Given this list of marker genes MYH14, ALDOA, RGS8, IL11, TAGLN2, NTN4, FABP4, ZNF827, NCDN, SCRN1, MIDEAS, EIF3J, PLEC, SYT2, FAP, SYN1, VWA7, GKN1, RTN4, MMP1, AKAP1, BDKRB1, KCNA2, SNCB, CDKN1A, TRAF3, GIT1, CYTOR, FAM180A, GFAP (glial fibrillary acidic protein), PSMD7, GABARAPL1, SRPK2, KRT19, RNF144B, GIGYF2, BRD2, EIF4G1, CFL2, MAP2, LRRC8E (leucine rich repeat containing 8 VRAC subunit E), MNT, EIF4E, PPP1R9B, PSMD11, SGK1 (serum/glucocorticoid regulated kinase 1), BCL9L, LAMA3, RAB3D, LAMB3, FADS3, MPV17, BAG2, HOXB3, HDAC3, UBE2E3, RUNDC3A, KBTBD8, CAMKK1, ENO2, ELL, MECP2, RPL23A, LRRC15, ABI3, PADI3, ABCD1, GPR3, PRSS36, LINC02908, PROK2, ABHD4, CA7 (carbonic anhydrase 7), DNAJC5B, NRAS, TIAL1, SHC3, PSME4, SLC24A4, PADI4, TNRC6A, NDRG2, SYNGR1 (NCBI Gene Id 9145), HMGA1, GTPBP2, LUC7L, FOXN1, ZNF436, SLC26A1, SLC26A9, TUBB4A, CHMP4B, RBBP7, PRX, KRT8, AP2A2, GNAI1, BMP2, HS3ST3B1, ZNF771, TNXB, DDIT3, NLK, CSTPP1, MAMDC2, EML3, ADRA1A, FOXA1, RAP1GAP2, BNIP3, ACADVL, ELK3, RGS2, PSMD4, TRIB1, SQSTM1, CAB39, PDZD9, DYNC1H1, CTNNAL1, GSE1 (Gse1 coiled-coil protein), CSMD3, AKT3, COQ8B, BBLN, HBEGF, ROM1, RB1CC1, TNIP3, P2RX6, EPHB2, LINC02694, MAST2, TGM3, F2RL2 (NCBI Gene Id 2151), H3-3B, S1PR2, RAB30, SPARC, GAPDH, TMEM151A, APOBEC1, STRADB, TAC1, ATP1B1, SNPH, TSR1, EEF1A2 (NCBI Gene Id 6669), VIT, MYB, GASAL1, PPP2CA, LAMC1, S100A10, TRIM47, PPP1R15A, DIAPH1, PCDH17, RPS6KA4, PHF23, CSRNP1, RPS20, TREX1, TRAK2, ECM1, DIRAS1, LINC00649, NR1D1, MRGPRF, CIDEC, HCN3, FGF12, EEF1A1, SRSF2, BICDL1, FAM81A, GNGT2, LPP, ACP3, CDH23, TPP1, GTF2B, TFE3, PTPRR, ANKRD28, SSH2, PIM1, MYBPH, COL7A1, MARK1, PCYT2, YPEL5, GDNF, DCTN2, SLC4A11 (solute carrier family 4 member 11), ADGRG4, WASF2, TLL1, LAMC2, NR1I3, DYSF, IL1RN, ELAVL2, SERTAD1 (SERTA domain containing 1), CACUL1, UBE2C, TNFRSF12A, ABCA2, DSC2, ZFAND5, CAPN6, GRIA1, CAPN12, EN1, SEC24D, ADGRG1, TRIM8, LY6G6C, PSMD12, HSPB8, ADAMTSL1, DYRK1A, OR2F1, CSF3, YIF1A, RIN1, RNF182, SH3RF2, CLRN1, DENND1B, LMNA, CHST1, BTK, C19orf33, ITPKC, OSBP, REXO2, NUAK1, AIF1L, RIPK4, LONRF3, KRT16, LTB4R2, NEK6, DLG4, KLHL41, ITGB4, LRRTM3, ENO1, RTL9, SLC6A5, TRAPPC3, MMP3, PKP3, FAM184A, PHLDA2, SYP, RAB34, SKIDA1, KRT25, EMP3, UCN2, GPX1, RELL2, here is a description of the gene set: Human Gene Set: BACH1_01 studied in species Homo sapiens Genes having at least one occurrence of the motif NNSATGAGTCATGNT in the regions spanning 4 kb centered on their transcription starting sites. This matches the BACH1 transcription factor binding site V$BACH1_01 (v7.4 TRANSFAC).